Given this list of marker genes TNFAIP8L1, PDE4B, NUDCD1, DNAJC21 (NCBI Gene Id 134218), PSMA2, LSS, CXCL2, NUDC, KCNQ1OT1, ST6GALNAC4 (NCBI Gene Id 27090), ERP44, FAS, PSTPIP2 (NCBI Gene Id 9078), ERGIC2, NKRF, DENND11, RSL1D1, KAZN, SLC35B3, ZNF202, TRAF6, KDM6B, PSMA7, TMEM171, GTF3C6, STARD4, USP10 (NCBI Gene Id 9100), EMILIN2, GNB4, KLF9, RUVBL1, CYP51A1, MET, ALAS1, MRPS18B (NCBI Gene Id 92039), TIMM8A, IL4I1, BATF3, GAS7, S100A6, TAF4B, FKBP4, MPHOSPH10, YRDC, FLT1, CD40, SF3B3, CMKLR1, TRMT10A, STX6, B3GNT7, DDX54, TARS1, RIOX2, SELENOS, UTP15, OTUD4, THUMPD1, RIPK2, UTP23, ARHGAP31, IPO7, PCGF6, SLC7A1, SUPV3L1, YARS1, EML4, HSPA8, FAM98A, STAP1, PDF, USP36, HK2, COPS8, ATP11B, PLA1A, F10, PPAT, ZC3H18, B3GALNT2, UAP1, GEM, URB2, MAGOH, HIVEP3, GTF2F2, RCN1, RANBP2, NFKBID, EIF3B, UBQLN4, TUBB4B, LFNG, PLAU, SLC39A14, OCSTAMP, PCBP1, GCLC, G3BP1, LTA4H, GPR146, ACLY, EDN1, NDUFAF4, IGSF9, ZFP36L1, SPINT1, EGR2, LCA5L, ORAI1, DLST, WDR1, IFI35, HR, CDH1, MAP2K4, ARL1, B3GNT2, BRIX1, NOL8, SLC17A9, NR4A3, PNP, RNF24, ID1, PLK3, RAB20, CASP4, MED13L (NCBI Gene Id 23389), GNL2, DNAJB11, RRP8, RANBP1, DCUN1D3, LSM12, UTP18, TSEN54, PROCR, ABCE1, DANCR, PMPCA, CORO2A, MFSD2A (MFSD2 lysolipid transporter A, lysophospholipid), UBXN2A, NSUN2, CMTM6, LZIC, MRPL17, STAT5A, ZMYND19, PRMT5, MYO1E, SH3PXD2B, TRAPPC4, KCNK6, ACTN1, LUC7L, PICALM, AFG2A, HECTD1, ZNF827, ATIC, SLC5A3, SERPINB2, PXDC1, EGR3, IRF4, TTC27, PLEK, PSMD7, PRR15, UBTD2, HEMK1 (HemK methyltransferase family member 1), NFKBIE, SLC35B1, MAGOHB, TLR2, SEMA6D, HSPH1, RARS1, PIM3, UBE2F, RARA, CHD1, INPP5A, IL6, ZC3H7B, AHR, STON2, SLC12A4, ICOS, SOCS1, CFLAR, GPR85, FCGR2A, PINX1, GPR171, BCL3, here is a description of the gene set: Human Gene Set: GSE26343_UNSTIM_VS_LPS_STIM_NFAT5_KO_MACROPHAGE_UP Gene expression from WT and NFAT5 KO primary macrophage cultures. Genes up-regulated in bone marrow-derived macrophages with NFAT5 knockout: control versus stimulated with LPS. studied in species Homo sapiens from publication Buxadé M, Lunazzi G, Minguillón J, Iborra S, Berga-Bolaños R, Del Val M, Aramburu J, López-Rodríguez C (PMID 22312110)